The following is a description of a gene set: species: Homo sapiens Determination of the asymmetric location of the liver with respect to the left and right halves of the organism. Human Gene Set: GOBP_DETERMINATION_OF_LIVER_LEFT_RIGHT_ASYMMETRY, and this is the list of marker genes: PKD2, CCDC39 (coiled-coil domain 39 molecular ruler complex subunit), CCDC40, NPHP3, DNAAF1, ZIC3